The following is a description of a gene set: species: Homo sapiens Genes down-regulated in comparison of stimulated CD4 Th1 cells at 12 h versus stimulated CD4 Th2 cells at 12 h. Human Gene Set: GSE22886_TH1_VS_TH2_12H_ACT_DN from publication Abbas AR, Baldwin D, Ma Y, Ouyang W, Gurney A, Martin F, Fong S, van Lookeren Campagne M, Godowski P, Williams PM, Chan AC, Clark HF (PMID 15789058) Immune cell-specific expression is one indication of the importance of a gene's role in the immune response. In order to identify such patterns, we set out to broadly profile gene expression in a variety of immune cells., and this is the list of marker genes: LRRC3, CHRD, RNF125, WIPF2, NPHP4, SNX10, MKS1, ARG2, TLL1, BPY2, GRIP2, DDR1, KCNJ5 (NCBI Gene Id 3762), PLA2G4A, KLF3-AS1, RPS27L, TRIM13, ZBTB22, AQR, SUSD4, TAT, CLCA2, SPRR3, MRC2, GBA3, GJB4, PKP3, SLC35A1, PCDH12, MTNR1B, RNF130, ESR1, TAC3, ASXL1, FMO5, CDC42EP2, MANBA, KSR1, H1-0, GALK1, IFNA16, AGRP, MIA, SOCS5, TMEM248, NAGLU (N-acetyl-alpha-glucosaminidase), TNRC6B, MYT1, MGAT4C, ZNF710, TBX3, MINDY2, BTN1A1, PMFBP1, GALNT3, GHR, SELENOW, ASCC1, C22orf31, GTPBP8, C2CD5, OFD1, CAMK4, MBOAT7 (membrane bound O-acyltransferase domain containing 7), CLCA3P, PMEL, ST8SIA4, VSNL1, ARSF, ARHGAP26, DENND5A, RAP1A, ZNF550, AR, SLC39A8, NOS1AP, H3C6, TRNAU1AP, ITPR1, RPS27A, POLI, COL8A1, AP3S1, HSDL2, CEP41, C6orf15, PCLO (piccolo presynaptic cytomatrix protein), SLPI (secretory leukocyte peptidase inhibitor), RNF167, TRH, TENM1, MBNL2, CSTB, TMED2, LGI1, MIPEP, PCDH9, CARF, RTCA, NYX, ME1, HLA-K, SRBD1, PITPNM1, SETX, ZNF337, C1orf116, SHBG, PTP4A1, RNF5, PCYT1A, KISS1, SNTG1 (NCBI Gene Id 54212), DCAF11, ARMCX5, TRIP11, CD164, CXCL10, HCAR3, PAQR5, RAB25, IL5, TFAP2C, FKRP, KRAS, NEAT1, LIF, SIGLEC9, AAMDC, RARB, INPP4B, TBC1D8B, IKZF3, RNF138, HIP1, CTNNA2, GP9, NEO1, CEP350, TNFAIP1, SPINT2, AKAP13, SLC39A14, MLANA (melan-A), GLB1, POU3F3, HOMER2, MT1M, CEP70, ESRRG, COL1A1, PDE10A (NCBI Gene Id 90632), ATRAID, TPMT, DIDO1, NMB, MMRN2, TNNI2, CNPY4, SMAD1, ZFYVE21, P3H2, GNG3, UGT8, GLS2, HPSE, NEK7, TMEM50B, FNBP1, CDC40, NIPSNAP3B, CD93, ACP2, OR7E87P, GPR132, GIPR, FKBP6, DIO2, RNF19A, NCSTN, LRRC37A2, MT4, GAD2, SNAI2, IL13, MT3, RHAG, KCNAB2, MC3R, GZMA (granzyme A), LIMA1, MEP1A, JAK2, TTC21B, ZNF419, TNKS, HERPUD1